The following is a description of a gene set: studied in species Mus musculus IL-3 signaling pathway Mouse Gene Set: WP_IL3_SIGNALING_PATHWAY, and this is the list of marker genes: Matk, Cdc42, Gata1 (NCBI Gene Id 14460), Kras, Atf2, Nfkb1, Atf1, Rara, Stat1, Mapk3, Mapkapk2, Cbl, Mapk1, Bax, Tnfrsf1b, Spi1, Slc2a1, Ptpn6, Fcer2a, Fes, Lyn, Bad, Ptk2, Mapk7, Ywhaz, Il3ra, Stat5b, Cish, Crkl, Hras, Rac1, Stat3, Lck, Gata2, Mmp2, Id1, Fyn, Bmx, Hck, Gsk3b, Gab2, Raf1, Kcnip3, Jak2, Pxn, Sos1, Rxra, Mras, Akt1, Pik3ca, Gsk3a, Ywhab, Vav1, Shc1, Tyk2, Jak1, Selp, Ptpn11, Map2k1, Prkcb, Gab1, Stat6, Crk, Il3, Rack1, Prkaca, Pik3r2, Mapk8, Pik3r1 (phosphoinositide-3-kinase regulatory subunit 1), Rap1a, Inpp5d, Grb2, Bcl2l11, Mapk14, Prkca, Bcl2l1, Pak1, Creb1, Socs3, Bcl2, Tec, Rapgef1, Rac2, Rps6kb2, Csf2rb, Stat5a, Vcl, Syk, Pik3cd, Socs2, Chek1, Mapk9, Foxo1, Mmp9, Hspb1, Ppp2ca, Src, Birc5, Dnm1